Given this list of marker genes CREBBP, SUCLG1, KCNA2, SLC38A3, SPATA7, CAPRIN1, FGD4, EXT2, SZT2, KCNB1, MAST1, DALRD3, PLA2G6, WARS1, NUDT2, DEAF1, RUSC2, ATP6AP2, SLITRK2, CEP104, DHX16, SACS, OGDH, DDHD1, SPTAN1, PNPLA6, HMBS, ATP6V1A, BSCL2, DNM1, LCA5, MCM3AP, ATP1A2, CYP2U1, RUBCN, PRNP, RNASEH1, PITRM1, PEX16, CACNA2D1, LRAT, ADSS1, ATXN8OS, DCC, CASK, ATP1A3, KCNC2, FBXO28, MAPK8IP3, PACS1, ACTL6B, GABBR2 (gamma-aminobutyric acid type B receptor subunit 2), SAMD9L, SCN1A, EIF2B1, HERC2, PMP22, AP2M1, EIF2B4, RNU4-2, CACNA1A, NEXMIF (NCBI Gene Id 340533, neurite extension and migration factor), STAG2, SHANK3, RNF170, UBA5, GAN (gigaxonin), CCDC88C, SMS, EIF2B2, PRKRA, TRAK1, VAC14, PEX10, NTRK2 (NCBI Gene Id 4915), BCL11B, OPA3 (NCBI Gene Id 8186), SGCA, XRCC1, XYLT2, SYNJ1, AARS1, SCN3A, MRE11, SYT14, YWHAG, GABRA2, NDUFA1 (NCBI Gene Id 4694), CELF2, NAT8L, CAMTA1, CLN8, KCNQ5, MAPT, GDAP1, ERCC6, PPP2R5D, AIFM1, MPZ, VWA3B, P4HTM, VPS41, SLC13A5, SYNGAP1, PACS2, POU4F1, EP300 (NCBI Gene Id 2033), PNPO, SCARB2, PAK1, CLCN4, TPI1, MPV17, CAMK2A, FZR1, CACNA1G, EEF1A2, MME, PDHX, MATR3, HTT, CHD2, ALDH4A1 (NCBI Gene Id 8659), GABRG2, NEFL, ERCC8, DHPS, CWF19L1, SLC6A1, ZSWIM6, SNUPN, CHD3, WLS, ENSG00000288330, PCNA, CDK19, NF2, PPP3CA, DAB1, SCN8A (NCBI Gene Id 6334), WWOX, DPM3 (NCBI Gene Id 54344), ATXN2, HPDL, OPA1, SLC2A1, CRAT, AP3B2, DARS2 (aspartyl-tRNA synthetase 2, mitochondrial), CBS, PDE10A, MGAT2, KDM5B, GABRA5, GLRX5, KIF1A, SLC1A2, RPE65, CNKSR2 (NCBI Gene Id 22866), TPP1, CLTC (NCBI Gene Id 9511), STUB1, KIF1C, FOXG1, MTFMT, ATP2B3, CIZ1, CYFIP2, HACE1, GARS1, SDHA, GRIN2D, PEX2, TRPC3, NECAP1, ATXN10, VPS13D, REEP1, PEX1, FGF12, HCN1, NUS1, EBF3, SPTBN2 (spectrin beta, non-erythrocytic 2), DOCK3, CACNA1B, DHDDS, ATP7A, GJB1, GABRB2, PMPCA, NDRG1, DAG1, KPNA3, PPP2R2B (protein phosphatase 2 regulatory subunit Bbeta), PARS2, QRICH1, here is a description of the gene set: Human Gene Set: HP_UNSTEADY_GAIT species: Homo sapiens Unsteady gait